The following is a description of a gene set: Mouse Gene Set: GOBP_NON_PROTEINOGENIC_AMINO_ACID_BIOSYNTHETIC_PROCESS studied in species Mus musculus The chemical reactions and pathways resulting in the formation of non-proteinogenic amino acids., and this is the list of marker genes: Plod2, Srr, Plod3, Cad, Abat, Upb1, Dpyd, Gad1, Park7, Aldh18a1, Otc, Slc1a3 (solute carrier family 1 (glial high affinity glutamate transporter), member 3), Gad2, Atp2b4, Slc38a1, Aldh1a1